The following is a description of a gene set: The portion of the plasma membrane surrounding a dendrite. Mouse Gene Set: GOCC_DENDRITE_MEMBRANE studied in species Mus musculus, and this is the list of marker genes: Reg1, Hcn1 (NCBI Gene Id 319874), Shisa9, Kcnc3, Gabra3 (gamma-aminobutyric acid type A receptor subunit alpha 3), Shisa6, Trpc2, Insr, Grin1, Gabra6, Gabra5, Gabarapl1, Atp6ap2, Gabrg2, Oprd1, Shisa7, Akap5, Hcn2, Gria1, Gabre, Dagla, Slc9a5, Gabra4 (gamma-aminobutyric acid type A receptor subunit alpha 4, NCBI Gene Id 14397), Clcn2 (NCBI Gene Id 404589), Trpv1, Cacng8, Sgce, Ngfr, Wls, Hpca, Gabrg1, Kcnc4, Slc12a5 (solute carrier family 12, member 5), Palm, Itga8, Thy1, Gabrg3, Gabra1 (NCBI Gene Id 14394), Kcnc1, Gabra2, Atf4, Cacna1d, Shisa8, Kcnb1, Gper1, Ppp1r9b, Gria2, Kcnc2, Ddn, Grin2a, Tacr3, Lamp5, Atp2b1 (ATPase, Ca++ transporting, plasma membrane 1), Mpp2 (NCBI Gene Id 93864), Atp2b2, Oprm1